Given this list of marker genes Zzz3, Abhd17a, Tada2a, Ppt2, Mbip, Sirt5, Nek3, Bex6, Ndst1, Brms1, Fnta, Mapt, Hdac2, Flna, Tada3, Desi2, Abhd17b (NCBI Gene Id 70566), Sgf29, Sirt3, Hdac1, Dr1, Hdac6, Yeats2, Nnmt (NCBI Gene Id 18113), Wdr5, Ccar2, Cpt1c, Prkaa1, Abhd12, Abhd17c, Bex4, Lyplal1, Hdac7, Lypla1, Hdac10, Ep300, Fry, Sirt2, Lypla2, Sirt4, Sirt6, Sirt7, Hdac4, Ppt1, Hdac3, Notum, Ncor2, Sirt1, Abhd13, Desi1, Ifng, Tppp, Kat14, Kat2a, Prkaa2, Abhd10, Hdac9, Ndn, here is a description of the gene set: species: Mus musculus The removal of an acyl group, any group or radical of the form RCO- where R is an organic group, from a macromolecule. Mouse Gene Set: GOBP_MACROMOLECULE_DEACYLATION